Given this list of marker genes Pcdhac1, Phlpp1, Fcgr1, Timm22, Pcdhac2, Angpt1, Ces3b, Pcdha5, Nup58, Smg1, Tex19.2, Slc12a5, Smndc1, Rilpl1, Clec9a, Camk1d, Rnf185, Pax3, Ears2, Tmem131, Rgp1, Plekha5, Hspb7 (NCBI Gene Id 29818), Dnase1l3, Rhobtb2, Acvr2a, Nrxn2, Tbc1d16, Fam136a (family with sequence similarity 136, member A), Rflna, Tmem47, Pcdha7, Tef, Mfrp, Mtr, Nutf2, Bace1 (beta-site APP cleaving enzyme 1), Bahcc1, Elovl5, Plaat1, Pcdha1, Smim1, Trp53inp2, Kazn, Chga, Pcdha9, Dda1, Pcdha4, Dcun1d3, Kdm4a, Tom1l2, Dot1l, Pth, Pcdha12, Pcdha6, Rhou, Traf1, Rab2a, Pcdha2, Foxp3, Adam1a, Pcdha3, Trappc14, Plekhb2, Kcnq1, Slc35e2, Strn, Pcdha11, Msl3, Ano6, Pcdha10, Polr1b, Pola1, Ces3a, here is a description of the gene set: Genes predicted to be targets of miRBase v22 microRNA mmu_miR_6990_3p in miRDB v6.0 with MirTarget v4 prediction scores > 80 (high confidence targets). Mouse Gene Set: MIR_6990_3P studied in species Mus musculus from publication Chen Y, Wang X (PMID 31504780)